Given this list of marker genes Cav1, Stard13, Lbr, Arhgef17, Racgap1, Arhgef1, Dlc1, Rtkn, Jup, Arhgef10, Mcam (NCBI Gene Id 84004), Lman1, Stk10, Prex1, Arhgap26, Pkn1, Depdc1b, Arhgef12, Arhgap18, Ccdc187, Flot2, Ophn1, Arhgef10l, Acbd5, Vangl1, Flot1, Fmnl2, here is a description of the gene set: studied in species Mus musculus part of: RHO GTPase cycle This event has been computationally inferred from an event that has been demonstrated in another species.<p>The inference is based on the homology mapping from PANTHER. Briefly, reactions for which all involved PhysicalEntities (in input, output and catalyst) have a mapped orthologue/paralogue (for complexes at least 75% of components must have a mapping) are inferred to the other species. electronically inferred by orthology from the curated human pathway Reactome Pathway: RHOC GTPase cycle